The following is a description of a gene set: Human Gene Set: REACTOME_GLUCONEOGENESIS studied in species Homo sapiens Gluconeogenesis, and this is the list of marker genes: TPI1, PGK1, G6PC1, GAPDH, PGAM1, G6PC2, ALDOA, SLC37A4, ALDOB, PGK2, ENO2, SLC37A1 (solute carrier family 37 member 1), PCK1, ENO3, ENO1, FBP2, PC, GPI, ALDOC (aldolase, fructose-bisphosphate C), PCK2, GAPDHS, ENO4, SLC37A2, PGAM2, G6PC3, FBP1